The following is a description of a gene set: Human Gene Set: GOBP_POSITIVE_REGULATION_OF_FIBROBLAST_GROWTH_FACTOR_RECEPTOR_SIGNALING_PATHWAY studied in species Homo sapiens Any process that activates or increases the frequency, rate or extent of fibroblast growth factor receptor signaling pathway activity., and this is the list of marker genes: ITGB1, NRXN1, FGFBP3, CTNNB1, FGFBP1, NPTN, SMOC2, DSTYK, PRKD2, MIR146A (microRNA 146a)